Given this list of marker genes COBL, LHPP, MDM4, ERGIC1, DNTT, LRFN2, XPNPEP2, SEC63, ABHD17B, LINC01507, LINC02202, ALPG, POLA2, VPREB3, TMEM217, RAG2, PPP3CC, XXYLT1-AS2, PRCD, GAB1 (NCBI Gene Id 2549), TOP2B, ZNF22-AS1, SMIM3, FXYD2, LINC00114, SEMA6A, PLIN3, LINC00426, LAPTM5, CD9, ZNF608, HHIP, MLXIP, ANKRD10, LUC7L3, SH3TC1, ERO1B (endoplasmic reticulum oxidoreductase 1 beta), LINC02982, GABPB1, CKMT2, RAG1, MPPED2, RHPN1, RFX5-AS1, SIAH2, ENSG00000227706, DBN1, GPSM1, ZCCHC7, CHD9, AQP5-AS1, TAF7, P4HA2, ATP1B3, BCR (BCR activator of RhoGEF and GTPase), HHIP-AS1, FHIT, EIPR1, TSPAN14, BLNK, ABCG2, SELENOF, CMTM7, SARDH, MME, PXDN, ELK3, SLC8A1-AS1, RIMKLB, HPS4, LY6H, NAV1, LINC01013, DNMT3L-AS1, MAP1LC3B, TP53INP1, STAG3, SYNE3, NUDT11, DUSP26, LCN6, ADPRM, CCDC81, AHDC1, RPS4Y2, ZNF22, EBF1, NKX6-3, GBP4, PPP2R2C, SOCS2, PPFIBP1, SH2D4B, RNF43, AQP5, VPREB1, FAM215B, MT1X, ERG, MAGED1, LINC00305, SMAD1, MTF2, MYO5C, AKAP12 (A-kinase anchoring protein 12), SPANXB1, NPY, GABPB1-AS1, S1PR4, JUP (junction plakoglobin), HMHB1, S100A1, ARPP21, MDM2, COX7A2L, SCHIP1, FAM241A, SNX2, NFIA-AS2, SERPINI1, QRSL1, GPR176, SLC35E3, CLEC14A, DOK4, here is a description of the gene set: species: Homo sapiens Human Gene Set: HAY_BONE_MARROW_CD34_POS_PRE_PC from publication Hay SB, Ferchen K, Chetal K, Grimes HL, Salomonis N (PMID 30243574)